The following is a description of a gene set: studied in species Mus musculus This event has been computationally inferred from an event that has been demonstrated in another species.<p>The inference is based on the homology mapping from PANTHER. Briefly, reactions for which all involved PhysicalEntities (in input, output and catalyst) have a mapped orthologue/paralogue (for complexes at least 75% of components must have a mapping) are inferred to the other species. electronically inferred by orthology from the curated human pathway part of: Metabolism of vitamins and cofactors Reactome Pathway: Metabolism of cofactors, and this is the list of marker genes: Coq7, Calm1, Aco1, Coq2, Pts, Gch1, Pdss2, Gchfr